Given this list of marker genes TMEM38B, METTL21C, FKBP1A, CALM2, JPH1, TMEM38A, PRKACA, CCL3, MIR1-1, MIR93, CLIC2, FASLG, ITPR1, GSTO1, CHD7, AKAP6, FKBP1B, JPH3, RYR2, GSTM2, DHRS7C (NCBI Gene Id 201140), CACNA1C, SLC8A1, JPH2, MIR133A1, SRI, CCR5, ASPH, RYR1, ANK2, CASQ1, ATP1A2, CASQ2, TRDN, NOL3 (NCBI Gene Id 8996), PLN, CALM1, RYR3, HRC, JPH4, CAMK2D, CALM3, DMD, PDE4D, here is a description of the gene set: studied in species Homo sapiens Human Gene Set: GOBP_RELEASE_OF_SEQUESTERED_CALCIUM_ION_INTO_CYTOSOL_BY_ENDOPLASMIC_RETICULUM The directed movement of calcium ion from endoplasmic reticulum to cytosol.